Given this list of marker genes Atp8a2, Atp8b2, Abcg1, Abcb4, Atp8b3, Abca1, Atp8b1, Atp11a, Atp10a, Atp8a1, Atp11c (NCBI Gene Id 54668), Abca7, Abcb1b, Abca2, Abcb1a, here is a description of the gene set: Mouse Gene Set: GOMF_FLOPPASE_ACTIVITY Catalysis of the movement of a lipid from the cytosolic to the exoplasmic leaflet of a membrane, using energy from the hydrolysis of ATP. species: Mus musculus